The following is a description of a gene set: Pathway Definition from KEGG: FLT3LG -> FLT3 -> GRB2 -> SOS -> RAS -> RAF -> MEK -> ERK studied in species Homo sapiens Human Gene Set: KEGG_MEDICUS_REFERENCE_FLT3LG_FLT3_RAS_ERK_SIGNALING_PATHWAY FLT3LG-FLT3-RAS-ERK signaling pathway. Pathway ID: N00217. Pathway type: Reference. Pathway class: nt06275 Acute myeloid leukemia., and this is the list of marker genes: SOS1, FLT3, GRB2, FLT3LG, MAPK3, KRAS, BRAF (NCBI Gene Id 673), MAPK1, SOS2, HRAS, MAP2K2, RAF1, MAP2K1 (mitogen-activated protein kinase kinase 1), NRAS, ARAF